The following is a description of a gene set: studied in species Mus musculus Human Gene Set: IWANAGA_CARCINOGENESIS_BY_KRAS_UP Phosphatase and tensin homologue deleted from chromosome 10 (Pten) is expressed aberrantly in non-small cell lung cancer cells, but the role of Pten in lung neoplasia has not been fully elucidated. In this study, we used a genetic approach to inactivate Pten in the bronchial epithelium of mice. Although, by itself, Pten inactivation had no discernible effect on bronchial epithelial histology, it accelerated lung tumorigenesis initiated by oncogenic K-ras, causing more rapid lethality than that induced by oncogenic K-ras alone (8 weeks versus 24 weeks of median duration of survival, respectively). Lung tumors arose in K-ras mutant, Pten-deficient mice that rapidly obstructed bronchial lumina and replaced alveolar spaces. Relative to K-ras mutant tumors, the K-ras mutant, Pten-deficient tumors exhibited more advanced histologic severity and more prominent inflammation and vascularity. Thus, Pten inactivation cooperated with oncogenic K-ras in promoting lung tumorigenesis. Cluster 3: genes up-regulated in lung tissue samples from mice with tumor-bearing genotypes (activated KRAS alone or together with inactivated PTEN). from publication Iwanaga K, Yang Y, Raso MG, Ma L, Hanna AE, Thilaganathan N, Moghaddam S, Evans CM, Li H, Cai WW, Sato M, Minna JD, Wu H, Creighton CJ, Demayo FJ, Wistuba II, Kurie JM (PMID 18281487), and this is the list of marker genes: SLC16A1, KDF1, DNM2, NCS1, WBP1, PAFAH1B3, CDKL5, RNF225, MAL, ARG2, TEDC2 (NCBI Gene Id 80178), PTGIR, MAGI3, IPO8, FERD3L, CHIA, COMMD3, DERL2, EPCAM, RNF123, DENND5B, CD55, TGOLN2, F7, CDC40, IGF1, BOD1L1, GLRX, B4GALNT1, CAMTA1, RNF181, GALNT3, SCRG1, FAM83G, IFNGR2, BCL9L, RAI14, ADCY7, FBN2, EGFL6, IBSP, MCOLN3, SLC9B1, OSGIN2, LDLR, VPS35L, NIPA1, DNAJC12, CTSZ, WNT5B, FUCA2, SPTLC3 (serine palmitoyltransferase long chain base subunit 3), KCNJ15 (NCBI Gene Id 3772), GJA1, MRC2, G2E3, MTUS1, TEKT5, ZNF598, FAM234B, HIPK3, SLC15A2, EMX2, SMARCA5, GPBP1L1, PTGR2, PC, FAM3C, CLDN12, EIF4G3, ASB9, ZNF419, ZNRF1, UQCC4, TADA1, HNMT, TGFBR2, EMB, SCHIP1, TFCP2L1, STK38, NRXN3, BRDT, MTMR1, CREBBP, PRNP, GLCCI1, CHRAC1, PDCD2, ST14, TRAPPC2, NRCAM, CXCL6, GDE1, WDR91, CNTN6, COA8, B3GAT1, CTPS1, RNF13, GOSR1, ASPH, AEBP2, TTN, CYGB, DHCR7, ECM2, SDC1, ATRX, SOX2 (SRY-box transcription factor 2), SOAT1, SPINT1, ATP6V1C1, PUF60, LDHD, DUSP15, CKMT1B, PCDHB13, PPP1R14C, EPHA1, CLU (NCBI Gene Id 1191), SCD, EPHA5, TCIM, FAM185A, IAPP, DUSP21, SERPINB12, HLA-B, CREB3L1, IFT43, PELI1, EPS8L1, ME1, SLA2, CKS1B, ELF5, ACBD5, LHX8-AS1, CSNK1A1, ATP1A1, DNAH8, URI1, HNF1A, NPTXR, PPP2R5C, SLC45A4, ACKR4, RUNX1, SUPT7L, GPR27, EREG, TSEN54, TENM2, SNX30, LDHA, POMGNT1, HOXD8, PNN, PEX7, GABRB3, INIP, GIMAP6, BEND4, LRG1, CTSH, ADK, FAM120A, SCP2, LGR6, SLC43A2, RAD51AP1